Given this list of marker genes Serpinb3a, Cd209e (CD209e antigen), Serpinb3d, Ilf3, Cd55, Myh9, Pvr, Slamf1, Cd209c, Xpr1, Timd5, Clec5a, Cd81, Axl, Serpinb3b, Slc7a1 (solute carrier family 7 (cationic amino acid transporter, y+ system), member 1), Timd6, Clec4g, Cd55b, Ceacam1, Hyal2, Plscr2, Dppa1, Slc3a2, Ace2, Tyro3, Hyal3, Cd209a, Dag1, Bsg, Cldn9, Nectin1, Cd300lf, Serpinb3c (NCBI Gene Id 381286), Tnfrsf14, Siva1, Slc20a2, Timd2, Cldn1, Cd300ld, Plscr1, Cldn6, Cd209b, Hyal1, Gpr15, Cd209d, Alb, Havcr1, Dpp4, here is a description of the gene set: Binding to a protein or protein complex from a different species, for example a pathogen molecule binding to a host protein. species: Mus musculus Mouse Gene Set: GOMF_EXOGENOUS_PROTEIN_BINDING